Given this list of marker genes FGG, PSMB2, PSMD8, MYD88, UBB, CALR, S100A8, PSMB1, CHUK, SEC61A2, CYBB, PSME2, SEC61G, SEM1, HLA-B, CD14, PSMD11 (NCBI Gene Id 5717), MRC2, SNAP23 (NCBI Gene Id 8773), PSMB3, PSMB5, NCF1, TLR4, HLA-C, FGA, PSMD1, SEC61A1, PSMA7, S100A1, PSMC6, NCF4, TAP2, TLR6, RPS27A, CTSS, PSMA5, PSMD7, CTSL, PSMC1, TLR2 (NCBI Gene Id 7097), BTK, HMGB1, SEC61B, TAP1, ITGB5, PSMD2, PSMA2, LY96, FCGR1A, CTSV, CD207, CD36, PSMA3, PDIA3, HLA-F, SEC22B, CYBA, NCF2, FGB, LNPEP, PSMC3, PSMB6, PSMB10, PSMC5 (proteasome 26S subunit, ATPase 5), TIRAP, PSMA4, PSMB7, HLA-A, PSME1, PSMB9, PSMC2, FCGR1BP, UBC, STX4, PSMC4, PSMD14, VAMP3, IKBKB (NCBI Gene Id 3551), UBA52, TAPBP, VAMP8, ITGAV, ADRM1, PSMB4, B2M (NCBI Gene Id 567), HLA-G, HLA-E, IKBKG, PSMA6, PSMD6, PSMD12, PSMB8, S100A9, MRC1, PSMD13, PSMD3, PSMA1, TLR1, here is a description of the gene set: Antigen processing-Cross presentation species: Homo sapiens Human Gene Set: REACTOME_ANTIGEN_PROCESSING_CROSS_PRESENTATION